The following is a description of a gene set: studied in species Mus musculus Genes down-regulated during pubertal mammary gland development between week 6 and 7. Mouse Gene Set: MCBRYAN_PUBERTAL_BREAST_6_7WK_DN from publication McBryan J, Howlin J, Kenny PA, Shioda T, Martin F (PMID 17486082) Expression microarray analysis identified over genes regulated during puberty in the mouse mammary gland. Most prominent were genes whose expression increased in parallel with pubertal development and remained high thereafter. Members of the Wnt, transforming growth factor-beta and oestrogen-signalling pathways were significantly overrepresented. Comparison to expression data from CITED1 knockout mice identified a subset of oestrogen-responsive genes displaying altered expression in the absence of CITED1. Included in this subset are stanniocalcin2 (Stc2) and amphiregulin (Areg). Chromatin immunoprecipitation revealed that ERalpha binds to oestrogen response elements in both the Stc2 and Areg genes in the mammary gland during puberty. Additionally, CITED1 and ERalpha localize to the same epithelial cells of the pubertal mammary gland, supporting a role for interaction of these two proteins during normal development. In a human breast cancer data set, expression of Stc2, Areg and CITED1 parallel that of ERalpha. Similar to ERalpha, CITED1 expression correlates with good outcome in breast cancer, implying that potential maintenance of the ERalpha-CITED1 co-regulated signalling pathway in breast tumours can indicate good prognosis., and this is the list of marker genes: Snrnp27, Cnn1, Bcl6, Ehf, Actg2, Serpina3k, Areg, Rps10, H19, Eps8, Ly6d, Sfxn1, Faap20, Cisd1, Dsp, Ift57, Wfdc18, F3, Mbp, St6galnac5, Serpinb11, Mup1, Tgif1, Mki67, Lsm14b, Utrn, Tagln, Gm4739, Timp1, Mal, Il33, Ccnl2, Igfbp2, Ugt8a, F2r, Slc4a4, Mpz, Vcan (NCBI Gene Id 71433), Plod2, Cdk1, Bpgm, Tnfrsf12a, Pla2g7, Kif22, Slc1a3, Upk3a, Acta2, Alas2, Irak1, Rnf149, Tnc, Fblim1, Ube2c, Unc50, Per3, Pttg1, Pdlim4, Dusp6, Sdc1, Tob2, Sfrp1, Palld, Apod, Cdc20, S100a8, Acsm3, Egr2, Cdca3, D17H6S56E-5, Myh11, Cap1, Mt2, Bltp3a, Pam, Atp5mk, Mup5, Slpi, Wfdc21, Gsta3, Nr1d1, Car4, Ccnb1 (NCBI Gene Id 268697), Ctla2a, Ifit3, Hcar2